The following is a description of a gene set: species: Homo sapiens Human Gene Set: WP_JAKSTAT_SIGNALING_IN_THE_REGULATION_OF_BETA_CELLS JAK-STAT signaling in the regulation of beta cells, and this is the list of marker genes: IFNG, PRL, EPOR, CCND2, MTOR, HRAS, IL6R, GH1, RPTOR, CISH, SOCS1, CCND3, IFNGR2, SOCS2, EPO, PRLR, STAT1, FOXM1, NRAS (NRAS proto-oncogene, GTPase), AKT2, SOCS3, STAT5A, AKT1, IL6, MLST8, CDK4, KRAS, IFNGR1, AKT1S1, JAK2, GHR, STAT5B, AKT3, STAT3